Given this list of marker genes Egfr, Atg5, Adora3, Alox12b, Ptger4, Prkce, Atg7, Sytl2, Map1lc3b, P2ry2, Cyba, here is a description of the gene set: studied in species Mus musculus Mouse Gene Set: GOBP_POSITIVE_REGULATION_OF_MUCUS_SECRETION Any process that activates or increases the frequency, rate or extent of the regulated release of mucus from a cell or a tissue.